The following is a description of a gene set: part of: ABC transporter disorders Reactome Pathway: Defective CFTR causes cystic fibrosis studied in species Homo sapiens Cystic fibrosis transmembrane conductance regulator (CFTR) is a low conductance chloride-selective channel that mediates the transport of chloride ions in human airway epithelial cells. Chloride ions plays a key role in maintaining homoeostasis of epithelial secretions in the lungs. Defects in CFTR can cause cystic fibrosis (CF; MIM:602421), a common generalised disorder in Caucasians affecting the exocrine glands. CF results in an ionic imbalance that impairs clearance of secretions, not only in the lung, but also in the pancreas, gastrointestinal tract and liver. Wide-ranging manifestations of the disease include chronic lung disease, exocrine pancreatic insufficiency, blockage of the terminal ileum, male infertility and salty sweat. The median survival of CF patients in North America and Western Europe is around 40 years., and this is the list of marker genes: PSMA2, PSMC1, UBA52, PSMA1, PSMB5, PSMC4, PSMA5, PSMA4, PSMD1, DERL1, PSMB2, ERLIN2, UBC, PSMD13 (proteasome 26S subunit, non-ATPase 13), DERL3, PSMB1, ADRM1, VCP, PSMC2, OS9, PSMB7, DERL2, CFTR, PSMC6, UBB, PSMD2, PSMD11, PSMD7, PSMD3, RNF185, PSMA7, ERLIN1, SEL1L, RNF5, PSMA3, PSMC3, PSMD14, ERLEC1, PSMD6, RPS27A, PSMD12, SEM1, PSMB3, PSMC5, PSMB4, PSMA6, PSMD8, PSMB6